Given this list of marker genes Dtnb, Col3a1, Itgav, Itgb1, Col5a1, Itgb4, Col4a2, Actg2, Sdc2, Utrn, Ddr1, Lama4, Sdc3, Actc1, Col11a2, Dag1, Sntb1, Sntg2, Fn1, Acta2, Itga6, Col5a2, Dtna, Sgcb, Megf6, Sgcg (NCBI Gene Id 74505), Col10a1, Col1a2, Col4a5, Sspn, Col2a1, Col4a3, Col4a4, Sgca (NCBI Gene Id 20391), Col11a1, Sgcd, Fgf2, Col5a3, Vtn, Col4a1, Sgce, Snta1, Col4a6, Itga2, Dmd, Sntb2, Actb, Drp2, Agrn, Itgb3, Sdc1, Sgcz, Acta1, Sdc4, Col1a1, Tgfb1, Ddr2, Actg1, here is a description of the gene set: species: Mus musculus Mouse Gene Set: REACTOME_NON_INTEGRIN_MEMBRANE_ECM_INTERACTIONS Non-integrin membrane-ECM interactions